The following is a description of a gene set: Abnormal choroid plexus morphology An abnormality of the choroid plexus, which is the area in the cerebral ventricles in which cerebrospinal fluid is produced by modified ependymal cells. studied in species Homo sapiens Human Gene Set: HP_ABNORMAL_CHOROID_PLEXUS_MORPHOLOGY, and this is the list of marker genes: GNAS, IFT43, TP53, SMARCB1, CHEK2, CDKN2A, ZBTB18, CTSC, NEDD4L, ZSWIM6, EXOC8, FOXF1, PHGDH, ZFX, NRAS, SETBP1, MDM2, NPHP3, FH